The following is a description of a gene set: Reactome Pathway: SMAC (DIABLO) binds to IAPs This event has been computationally inferred from an event that has been demonstrated in another species.<p>The inference is based on the homology mapping from PANTHER. Briefly, reactions for which all involved PhysicalEntities (in input, output and catalyst) have a mapped orthologue/paralogue (for complexes at least 75% of components must have a mapping) are inferred to the other species. electronically inferred by orthology from the curated human pathway species: Mus musculus part of: SMAC, XIAP-regulated apoptotic response, and this is the list of marker genes: Casp7